The following is a description of a gene set: Human Gene Set: GOBP_LATERAL_VENTRICLE_DEVELOPMENT studied in species Homo sapiens The process whose specific outcome is the progression of the lateral ventricles over time, from the formation to the mature structure. The two lateral ventricles are a cavity in each of the cerebral hemispheres derived from the cavity of the embryonic neural tube. They are separated from each other by the septum pellucidum, and each communicates with the third ventricle by the foramen of Monro, through which also the choroid plexuses of the lateral ventricles become continuous with that of the third ventricle., and this is the list of marker genes: ATP1B2 (ATPase Na+/K+ transporting subunit beta 2), KDM2B, DPCD, TSKU, NUMB, RPGRIP1L, MYH10, NUMBL, UCHL5, AQP1, PAX5 (NCBI Gene Id 5079), CDK6, DNAH5